The following is a description of a gene set: species: Homo sapiens Reactome Pathway: FASTK family proteins regulate processing and stability of mitochondrial RNAs Fas-activated serine/threonine kinase (FASTK) and its homologs FASTKD1-5 each contain three conserved domains (FAST_1, FAST_2, and RAP) that bind RNA. FASTKD1-5 and the short isoform of FASTK localize to mitochondria where they participate in regulating the processing and stability of RNA.<br>FASTK interacts with the 3' end of the MT-ND6 mRNA and protects the mRNA from degradation by the degradosome, SUPV3L1:PNPT1. The MT-ND6 mRNA is unusual in being processed from the large L-strand precursor without flanking tRNA genes and thus without canonical processing by RNAse P and RNase Z. FASTK may, therefore, participate in an uncharacterized non-canonical mechanism of RNA processing or protect 3' ends produced by such a mechanism.<br>FASTKD1 acts to reduce the abundance of the MT-ND3 mRNA by an uncharacterized mechanism.<br>FASTKD2 binds the 16S rRNA and the MT-ND6 mRNA and participates in their processing and expression. FASTKD2 interacts with several mitochondrial proteins including MTERFD1, TRUB2, WBSCR16, and NGRN. <br>FASTKD3 increases levels of five mitochondrial mRNAs (MT-ND2, MT-ND3, MT-CYB, MT-CO2, and the MT-ATP8/6 bicistronic mRNA) and increases translation of MT-CO1 mRNA through uncharacterized mechanisms.<br>TBRG4 (FASTKD4) binds most RNAs transcribed from the H-strand and enhances the expression levels of MT-ATP8/6, MT-CO1, MT-CO2, MT-CO3, MT-ND3, MT-CYB, and MT-ND5 mRNAs. TBRG4 stabilizes MT-CO1, MT-ND3, and MT-CO2 mRNAs and assists the processing of MT-ND5 and MT-CYB mRNAs.<br>FASTKD5 binds 12S rRNA and all mRNAs except MT-ND3 and reduces levels of MT-ATP8/6, MT-CO1, MT-CO3, MT-ND5, and MT-CYB mRNAs.. part of: Mitochondrial RNA degradation, and this is the list of marker genes: MT-ND1, MT-ATP6, FASTK, MT-ND4L, FASTKD5, MT-CYB, MT-CO3, MT-RNR2, MT-CO1 (mitochondrially encoded cytochrome c oxidase I, NCBI Gene Id 4512), MT-ND3, MT-ATP8, MT-ND6, MT-CO2, MT-ND2, FASTKD2, MT-RNR1, MT-ND4 (NCBI Gene Id 4538), MT-ND5, TBRG4